Given this list of marker genes EOGT (NCBI Gene Id 79580), DLX5, HOXA13, BHLHA9, SALL1, GDF5, ADA, NOTCH2, TBL1XR1, GNAS, CTBP1, NELFA, RMRP (RNA component of mitochondrial RNA processing endoribonuclease), RNU4ATAC, SMARCA4, DLL4, ROBO1, HEATR3, BMP2, ALMS1, PDE4D, HOXD13, LIG4, DCLRE1C, MIA3, PRKG2, IFT140, DOCK6, SMAD4, NSDHL, CPLX1, NOTCH1, PORCN, ASXL1, NSD2, NOG (NCBI Gene Id 9241), PIGG, PTH1R, LMBR1 (NCBI Gene Id 85501), IFT122, ASAH1, GPC3, ABCC9, GRIP1, KAT6A, SALL4, C12orf57, TPR, GPX4, TGDS, RBPJ, NEK1, ALOX12B, DACT1, DYRK1A, TBX22, TNNT3, EIF4A3, WASF1, DNMT3A, CTCF, OFD1, ARID1B, ERF, KCNH1, COL2A1, ZFX, MAP3K20, ZMIZ1, HDAC4, MYCN, GJA1, ADAMTS2, SLC26A2, ROR2, HBA1, PIGF, NPR2, SMOC1, TBX5, RAB3GAP2, GPC4, FLNA, PIGV, LRP4, CHSY1 (NCBI Gene Id 22856), GHR, PHF6, SHOX, ARHGAP31, KMT2A, RAG1, ACVR1, LETM1, COX4I1, UBAP2L, RIPK4, APC, ERI1, ASCC3 (activating signal cointegrator 1 complex subunit 3), PRKAR1A, SOX9, FGFR2, FGFR3, PUF60, IL7R, WNT7A, ADNP, BPNT2, FGFRL1, SVBP, SF3B4, ALOXE3, FGFR1 (fibroblast growth factor receptor 1), EP300, HBA2, IHH, SPECC1L, KCNN3, CHST11, KCNJ8, CHD7, MGP, BMPR1B, ARSL, TRPV4, PTHLH, IL2RG, TBX3, DHCR7, B3GLCT, GLI3, FIG4, VAC14, WNT10B, LMNA, RAG2, FLI1, here is a description of the gene set: Aplasia/Hypoplasia of toe Human Gene Set: HP_APLASIA_HYPOPLASIA_OF_TOE species: Homo sapiens Absence or hypoplasia of toes.